The following is a description of a gene set: studied in species Homo sapiens Human Gene Set: GOBP_NEGATIVE_REGULATION_OF_SUPRAMOLECULAR_FIBER_ORGANIZATION Any process that stops, prevents or reduces the frequency, rate or extent of fibril organization., and this is the list of marker genes: TOGARAM2, CDH5, SHANK3, TMOD4, SLIT2, MAP1B, FGF13, TMOD1, CAPZB, CHADL, HDGFL3, DNAI3, SMAD4, CTNNA2, PFDN5, BBS4, MIR214, WASHC2C, TMOD2, DLC1, PRKCD, KANK3, GAS2L2, DIAPH3, VIL1, SPTBN5, PHLDB2, RHPN2P1, LDLR, SPEF1, GSN, DYRK1A, CORO1B, IAPP, CAPZA2, PFDN2 (prefoldin subunit 2), PFDN1, APC2, GAS2L1, S1PR1, MAPRE1, TMOD3, STMN1, TRIOBP, MKKS, SHANK1, OAZ3, PIK3CA, PFN1, SPTA1, PICK1, ATXN7, TPX2, CRYAB, SNCA, APC, PIK3R1, MET, VBP1 (NCBI Gene Id 7411), CLASP1, MIR149, TWF2, LIMA1, LMOD2, TWF1, FKBP4, AVIL, SPECC1L, MIR21, APOE, VILL, RHPN2, DMTN, GMFB, TUBB4A, PFN2, EMILIN1, RDX, ADD2, FRMD7, SPTB, MAP6D1, HDAC6, ARHGAP28, MTPN, CRACD, SWAP70, MAP2, MYOC, TMSB4X, PPFIA1 (NCBI Gene Id 8500), LMOD3, TREM2, CORO1A, TTBK2, INPP5J, ARPIN, SPTBN2, SPTBN4, BBOF1 (basal body orientation factor 1), ARAP1, CGNL1, ADD1, SSH1, SSH3, WASF2, KANK1, CAMSAP2, WDR47, SPTBN1, CARMIL2, CLIP3, CAPG, ARHGEF7, TAOK1, RHPN1, TMEFF2, HSPG2, KANK4, MYADM, CCDC88C, ARHGAP6, CIB1, CLASP2, MID1IP1, BMERB1, INPP5K, MIR20A, KANK2, CAV3, ADD3 (adducin 3), SPTAN1, MIR31, MIR29B1, GMFG, NAV3, HIP1R, CLU, CORO2B, LMOD1, SSH2, CYRIB, TRIM54, ARHGEF18, CKAP2, FLII, TJP1, MID1, TACSTD2, HSPA8, TBCD, ARFGEF1, MIR138-1, ASB2, CAPZA1, PFDN6, CARMIL1, PRKN, PAK2, CAPZA3, STMN2, WAS, EPS8, PFDN4, CFL1, KATNB1, ARHGEF2, F11R (NCBI Gene Id 50848), PLEKHH2, SVIL, SCIN, EML2